Given this list of marker genes Prkag1, Ldhb, Hnf4a, Pycr2, Kmo, Elovl5 (ELOVL fatty acid elongase 5), Pnpla8, Mthfr, Tecr, Cyp2c23, Apoc2, Akr1b1, Cd74, Acmsd, Csad, Rdh9, Apoa5, Insig1, Acacb, Cthrc1, Plod2, Fcer1a, Xiap, Akr1a1, Fads2, Pcbd1, Mri1, Alox12b, Cth, Mthfd2, Amacr, Carns1, Gip, Bhmt, Qki (quaking, KH domain containing RNA binding), Asah2, Rac1, Shmt1, Gstp3 (NCBI Gene Id 225884), Atp2b4, Phgdh, Fabp5, Sco1, Acss2, Agt, Alox5ap, Aldh1a1, Mthfd1l, Aloxe3, Cyp4a30b, Mecr, Acaa1b, Pex2, Reg3g, Cyp27a1, Gls, Avp, Elovl6, Baat, Ldhc, Acsm4, Thnsl2, Acsm2, Pla2g2a, Nr1h2, Gulo, Scd1, Uros, Prkaa1, Cln3, Aldh8a1, Gne, Acsbg2, Klhl25 (kelch-like 25), Tbxas1, Abcd2, Mtr, Pnliprp1, Pecr, Acss1, Alox5, Apoa4, Pklr, Erlin1, Lipg, Mthfd2l, Ggt1, Mgll, Prkag3 (NCBI Gene Id 241113), Prg3, Cbr4, Ilvbl, Hacd1, Nanp, Otc, Mlxipl, Lipc, Acsl1, Akr1c18, Asns, Anxa1, Pla2g4a, Abcd3, Tha1, Park7, Decr2, Mapk9, Abhd3, Gad1, Bcat2, Mgst2, Bhmt2, Gstm6, Upb1, Avpr1a, Abhd1, Fads3, Fgfr4, Acsbg3 (acyl-CoA synthetase bubblegum family member 3), Lgsn, Mif, Srr, Stard4, Gstm2 (NCBI Gene Id 14863), Scap, Cyp7b1, Acsl4, Bin1, Acox1, Scd4, Aass, Pdk4, Abhd2, Hpgds, Sirt1, Elovl7, Acadvl, Aldh18a1, Pycr3, Aldh1a3, Plp1, Scd2, Pla2g3, Noxred1, Slc1a3, Rdh16f2, Cdo1, Acox2 (acyl-Coenzyme A oxidase 2, branched chain), Sds, Agxt2, Acsm3, Elovl3, Asl, Apip, Mgst3, Adi1, Sephs1, Malrd1, Acot7, Nags, Cyp4a12b, Ptges2, Psat1, Fads6, Gstm4, Pla2g10, Bcat1, Ass1, Alox15, Acsbg1, Ces1a, Lta4h, Gstp2, Cbs, Ugp2, Pla2g4f, Nr1h3, Bcl10, Prmt3, Ptgs1, Elovl1, E2f1, Errfi1, Aasdhppt, Akr1d1, Wdtc1, Ces1e, Ltc4s, Rbp1, Elovl2, Degs1, Pnlip, Ces1h, Sphk1, Prox1, Prkab2, Oxsm, Lpl, Gad2, Acaca, Kat2b, Extl3, Shmt2, Htd2, Acly, Ggt5 (NCBI Gene Id 23887), Fasn, Gamt, Prxl2b, Rdh10, Ces1f, Mtap, Acsf3, Abcc1, Ces1c, Cyp8b1, Cyp7a1, Fads1, Ugdh, Abat, Bhmt1b, Elovl4, Mtrr, Ehhadh, Mcat, Abcd1, Ubr4, Sephs2, Ceacam1, Mlycd, Slc27a2, Gstm3, Syk, Got2, Tecrl, Pah, Eif6, Ceacam2, Agxt, Mid1ip1, Cad, Pla2g5, Apoc3, Slc27a5, Rdh16, Rdh19, Slc25a12, Cyp39a1, Hsd17b8, Srebf1, Fmo3, Sirt2, Ptgis, Fmo1 (NCBI Gene Id 14261), Pkm, Il1b, Haao, Rdh1, Hao1, Fads2b, Pycr1, Gatm, Psph, Prkab1, Hsd17b12, Gstm7, Tmem135, Fgf15, Htt, Prkaa2, Lpgat1, Gstp-ps, Ido1, Edn1, Enoph1, Trib3, Daglb, Ptges (NCBI Gene Id 80632), Dhrs9, Kynu, Edn2, Acsm1, Rgn, Myo5a, Ldha, Pnliprp2, Mthfd1, Ugt1a6a, Gstm1, Scp2, Pcbd2, Cyp4a14, Hacd2, Cyp4a10, Slc45a3, Dpyd, Hnf1a, Glul, Ptges3-ps, Acsm5, Cyp4a12a, Cyp4a31, Hacd4, Erlin2, Star, Acot8, Ndufab1 (NADH:ubiquinone oxidoreductase subunit AB1), Ptges3, Fa2h, Nr1d1, Aldh1a2, Acsl3, Ces1d, Nans, Slc38a1, Pibf1, Cyp1a1, Ces1g, Ptgds, Hacd3, Gsto1, Hsd17b10, Got1, Hsd17b4, Plod3, Gstp1, Apoc2l, Olah, Acaa1a, Acadl, Insig2, Lias, Cyp4a29, Dcaf5, Asnsd1, Prkag2, Cyp4a32, Gls2, Alox8, Per2, Got1l1, Oat, Pla2g1b, Alox12, Hoga1, Brca1, Ces1b, Apoc1, Scd3, Ptgs2, here is a description of the gene set: species: Mus musculus Mouse Gene Set: GOBP_ORGANIC_ACID_BIOSYNTHETIC_PROCESS The chemical reactions and pathways resulting in the formation of organic acids, any acidic compound containing carbon in covalent linkage.